Given this list of marker genes Slc24a4, Letm1, Slc8a2, Slc24a5, Slc30a10, Slc24a3, Slc8a1, Slc8a3, Ghitm, Slc24a2 (NCBI Gene Id 76376), Slc8b1, Slc24a1, here is a description of the gene set: species: Mus musculus Mouse Gene Set: GOMF_CALCIUM_MONOATOMIC_CATION_ANTIPORTER_ACTIVITY Enables the transfer of a solute or solutes from one side of a membrane to the other according to the reaction: Ca2+(in) + cation(out) = Ca2+(out) + cation(in).